The following is a description of a gene set: Human Gene Set: REACTOME_FORMATION_OF_INCISION_COMPLEX_IN_GG_NER Formation of Incision Complex in GG-NER studied in species Homo sapiens, and this is the list of marker genes: RAD23A, CUL4A, PIAS3, RPA3, UBC (ubiquitin C), USP45, ERCC5, PARP2, CETN2, SUMO3, ERCC3, GTF2H4, RPS27A (ribosomal protein S27a), UBB, GTF2H1, XPA, RPA1, CUL4B, GTF2H3, ERCC1, DDB2, UBE2V2, DDB1, ERCC2, PARP1, CCNH, RPA2, CDK7, SUMO2, UBE2N, CHD1L, UBE2I, RAD23B, RBX1, ERCC4, PIAS1, UBA52, XPC, MNAT1, SUMO1, GTF2H2, GTF2H5, RNF111